The following is a description of a gene set: species: Homo sapiens The series of events in which a temperature stimulus (hot or cold) is received and converted into a molecular signal. Human Gene Set: GOBP_DETECTION_OF_TEMPERATURE_STIMULUS, and this is the list of marker genes: TRPV1, SCN11A, WDR47, SCN9A, DRGX, ASIC3, HTR2A, SCRN3, RHO, NTSR1, ANO1, TAC4, NGFR, DISC1, PRDM12 (PR/SET domain 12), ANO3, LXN, TAC1, CXCL12, OPN4, EPHB1, MMP24, COMT, GRIK2, NTRK1, ADORA1, NR2F6